Given this list of marker genes TTLL7, TTLL6 (NCBI Gene Id 284076), TTLL5, TTLL11, TTLL4, here is a description of the gene set: studied in species Homo sapiens Human Gene Set: GOMF_PROTEIN_GLUTAMIC_ACID_LIGASE_ACTIVITY_INITIATING Catalytic reaction: ATP + L-glutamate + L-glutamyl- = ADP + H+ + L-gamma-glutamyl-L-glutamyl- + phosphate.